The following is a description of a gene set: In the present study we used Affymetrix oligonucleotide microarrays to produce gene transcription profiles for the major leukocyte types in humans. This comprehensive dataset enabled us to not only establish which genes were expressed in each leukocyte type, but also which genes were expressed in each subset after activation. The used of a comprehensive dataset of gene profiles from all the major human leukocyte subsets enabled a novel and powerful means for identification of genes associated with single leukocyte subsets, or different immune paradigms. from publication Jeffrey KL, Brummer T, Rolph MS, Liu SM, Callejas NA, Grumont RJ, Gillieron C, Mackay F, Grey S, Camps M, Rommel C, Gerondakis SD, Mackay CR (PMID 16474395) Genes up-regulated in comparison of effective memory CD4 T cells versus Th2 cells. studied in species Homo sapiens Human Gene Set: GSE3982_EFF_MEMORY_CD4_TCELL_VS_TH2_UP, and this is the list of marker genes: GUCY1B2, AQP1, GPR17, UBE3A, L1CAM, IRF9, DDHD2, TRPM8, ANO3, CROCCP2, RNF44, SAP30L-AS1 (NCBI Gene Id 386627), STOM, TCEAL9, DOCK4, CCPG1, COL4A3, CORO2A, STOML1, ASB8, COL13A1, FKRP, KRT20, PMEL, ANGEL1, SCGB1D2, CYP4F11, F8, AXIN1, TLX2, MGAT3, UVRAG, ZNF532, CEP68, MAPKAPK5, PEX5L (NCBI Gene Id 51555), ZNF480, ULK4, GIGYF2, ZNF337, MARCO, KIF5C, TCF20, GARNL3, LONP2, FAM204A (family with sequence similarity 204 member A), DCLK1, RPS10P5, ARHGAP45, PAN2, PSORS1C2, IAPP, MYO1B, SCAPER, ZNF556, XKR8, MFAP5, BTN2A1, POMZP3, MTO1, TSC22D3, AQP3, DIO3, SHBG, SEZ6L, CNTNAP1, FCGBP, AKAP9, FZD8, ALOX15B, SCN2B, MAST4, BIN1, SP100, OR3A1, AK1, NPRL2, LCOR, PPFIBP2, CACNA1H, CLIC5, PLXDC1, CNIH3, HERC1, PRRC2B, ANXA1, NAV3, LGALS8, MMP2, KLRF1, OR10C1, PROCR, BDKRB1, NR1D2, PAPOLG, CYP1A1, APLP1, LUZP1, ZNF335, ENTR1, HNF4G, MAGEA4, PSME4, ANKRD34C, HSPA1L, PCSK7, NRG2, TBX1 (T-box transcription factor 1), MYO6, RALGPS1, ZSCAN26, EPHA2, RAB27B, HEXA, SLC10A3, ARAP2, CYB5R1, ZAP70, GHSR, E2F5, GDPD5, PDE10A, SECISBP2, GPATCH8, FBP1, TAF4, PBXIP1, ZNF721, CD44, GABRP, PHF24, GRPR, MBD1, AGPAT4, INAVA, AP5Z1, LILRA1, AKR1C3, SRSF5, MSL3 (NCBI Gene Id 25867), ALX1, STEAP1 (STEAP family member 1), RASGRP1, MKRN1, DEFB126, SPDEF, KBTBD2, GUCA2A, PI3, DAO, PCDHB13, GAGE1, PTPRU, EEF1D (eukaryotic translation elongation factor 1 delta), FAM30A, ITIH4 (inter-alpha-trypsin inhibitor heavy chain 4), LPIN2, CHCHD7, ADCK2, UBOX5, DOCK6, ACTN2, HLA-DRB1, GCGR, IL11RA, MACF1, SLC30A3, ELF3, CD300A, ZBTB25, POLR1D, SON, AHCYL2, ECE1, ZIC1, ITGB4, R3HDM2, ACSS3, TMEM50A, SGSM2, SLC6A2, EZH1, ADAMTS8, BTG1, ENPP4, IL19, RCBTB2, LINC00623, SLC16A5, QSER1, PLEKHH3, ITGA10, ENTPD4, LPIN1 (lipin 1), KDM7A, MALT1, GIN1, PLXND1